The following is a description of a gene set: Fingerprint intracellular accumulation of autofluorescent lipopigment storage material An intracellular accumulation of autofluorescent lipopigment storage material in a trabecular or fingerprint-like pattern. Human Gene Set: HP_FINGERPRINT_INTRACELLULAR_ACCUMULATION_OF_AUTOFLUORESCENT_LIPOPIGMENT_STORAGE_MATERIAL studied in species Homo sapiens, and this is the list of marker genes: CLN8, CLN5, CLN3 (CLN3 lysosomal/endosomal transmembrane protein, battenin), CLN6, KCTD7, DNAJC5